The following is a description of a gene set: Class I MHC mediated antigen processing & presentation Human Gene Set: REACTOME_CLASS_I_MHC_MEDIATED_ANTIGEN_PROCESSING_PRESENTATION studied in species Homo sapiens, and this is the list of marker genes: SEC24C, HECTD2 (HECT domain E3 ubiquitin protein ligase 2, NCBI Gene Id 196026), TAPBP, PSMA5, FBXO21, TIRAP, RNF6, UBA3, FBXL15, PSME2, HSPA5, CDC27 (NCBI Gene Id 996), ERAP1, ASB2, UBA6, SEC24A, FBXL22, HLA-B, TPP2, SEC31A, THOP1, ELOC, CUL5, KLHL42, TRAIP, FBXL4, KLHL41, CUL1, PSMD1, PSMC3, FBXW10, RNF182, UBE2Q1, CD207, BLMH, UBE2E1, FBXO30, UBAC1, SH3RF1, PSMD6, SPSB2, UBE3C, KBTBD8, ZNRF2, PSMA1, UBC, PSMA3, FGB, FBXW2, ANAPC5, NCF2, PSMB7, CCNF, PSMC6, PSMC2, PSME1, DTX3L, SNAP23, PSMB2, LRR1, TRIM9, TRIP12, UBE2G1, CYBB, UBE2V1, ASB13, CBLL2, KLHL2, LNPEP, PSMB4, SIAH2, BTK, UBA7, TLR1, ATG7, UBA5, UBR4, FBXO27, TRIM32, TRIM4, CUL3, UBE3B, SKP2, RNF41, TLR4, UBE2N, PSMB9 (NCBI Gene Id 92051), UBE2O, MIB2, UBE2L6, UBE2G2, SMURF2, NCF1, AREL1, UBE2F, PSMD3, HLA-C, SKP1, KLHL5, RNF114, RPS27A, ITGB5, ADRM1, FBXO44, ASB3, DET1, PSMD8, SMURF1, UBE2V2, LY96, WSB1, MRC1, UBE2J1, UBE2M, ASB6, FBXL16, RNF7, UBE2D2, UBE3A, BCAP31, S100A8, TRAF7, PSMC5, PSMB5, CHUK, CDC26 (NCBI Gene Id 246184), RNF115, RNF19A, UBE2S, HLA-A, IKBKG, TRIM69, LRRC41, TRIM71 (NCBI Gene Id 131405), SPSB4 (splA/ryanodine receptor domain and SOCS box containing 4), UBE2W, ASB1, TRIM21, HACE1, FBXO9, ASB17, KLHL9, CBLB, HUWE1, SEC24D, KCTD6, FBXO6, CDC34, SEC23A, KEAP1, UBE2K, TRIM41, UBE2L3, ZBTB16, CTSS, BTRC, FBXO17, PSMD7, CUL2, KBTBD6, PSMD2, PSMD14, TRIM11, SPSB1, RBX1, MGRN1, WWP1, UBE2A, SOCS1 (NCBI Gene Id 8651), ANAPC1, UBE2Q2, FBXL7, UBE2R2 (NCBI Gene Id 54926, ubiquitin conjugating enzyme E2 R2), ASB12, RNF4, IKBKB, CYBA, FBXO11, ASB18 (ankyrin repeat and SOCS box containing 18, NCBI Gene Id 401036), ASB4, KBTBD13, FBXO7, GAN, UBE2E3, HERC1, CD14, ASB15, UBE2C, ASB8, LTN1, ANAPC7, HERC5, PJA1, FBXO41, PSMA4, UBR1, UBB, RNF126, UBE2H, FGG, UBA1, RNF213, PSMB10, TRIM36, SEC61B, CDC20, HECTD3, PJA2, UBE2B, UBE2U, PSMC1, KBTBD7, FBXW8, MYD88, HLA-E, FBXW11, PRKN, HERC6, CDC23, RNF144B, UBR2, DZIP3, VAMP8, UBE2J2, ANAPC13, LMO7, STUB1, FBXW7, CUL7, HLA-G, FBXO10, SEC13, UNKL, SEM1, LNX1, ASB14, ASB10, PSMB1, BTBD1, HLA-F, RNF217, ASB5, HECTD1, ELOB, KLHL25, FBXL20 (F-box and leucine rich repeat protein 20), B2M, ANAPC10, HMGB1, RNF138, NCF4, FBXO2, NPEPPS, RCHY1, RNF130, TAP1, PDIA3, LONRF1, HERC2, STX4, TRIM37, PSMD11, PSMA6 (proteasome 20S subunit alpha 6), TLR6, SEC22B, CTSL, HERC3, ARIH2, UFL1, UBE2D4, CDC16, ITCH, PSMB6, PIK3C3, RNF123, KLHL13, TRIM50, UBE4A, S100A9, FBXO31, PSMD12, CANX, FBXL18, ANAPC2 (anaphase promoting complex subunit 2), RLIM, SEC61A2, PSMA2, TRIM39, FCGR1A, ASB16, MRC2 (mannose receptor C-type 2), KLHL3, FBXL19, SEC61A1, MKRN1, RBCK1, UBE2D1, PSMC4, FZR1, FCGR1BP, UBOX5, FBXL5, KLHL22, UBE3D, FBXW4, FBXL14, NEDD4, SIAH1, PSMB8 (proteasome 20S subunit beta 8), SOCS3, ASB7, UBE2Z (ubiquitin conjugating enzyme E2 Z), LRSAM1, VAMP3, FBXO22, SEC61G, FBXW5, TLR2, ASB9, SEC24B, KLHL11, ASB11, RNF25 (NCBI Gene Id 79103), FBXL3 (NCBI Gene Id 26224), BTBD6, KLHL21, VHL, FBXO40, RBBP6, CTSV, UBA52, GLMN, NEDD4L, MEX3C, FGA, DCAF1, ITGAV, PSMD13, UBE2D3 (ubiquitin conjugating enzyme E2 D3), KCTD7, SAR1B, PIK3R4, PSMA7, CALR, RNF111, ANAPC11, CD36, ERAP2, FBXW9 (F-box and WD repeat domain containing 9), FBXL13, FBXO15, BECN1, FBXO4, TRIM63, FBXW12, ZNRF1, S100A1, RNF220, ANAPC4, RNF14, RNF34, FBXL12, HERC4, UBE2E2 (ubiquitin conjugating enzyme E2 E2), MYLIP, RNF19B, HECW2, KLHL20, PSMB3, FBXO32, TAP2, FBXL8, ATG14 (autophagy related 14)